The following is a description of a gene set: part of: L1CAM interactions L1 functions in many aspects of neuronal development including axon outgrowth and neuronal migration. These functions require coordination between L1 and the actin cytoskeleton. F-actin continuously moves in a retrograde direction from the P-(peripheral) domain of the growth cone towards the growth cone's C-(central) domain. L1, attached to the actin cytoskeleton via membrane cytoskeletal linkers (MCKs) such as ankyrins (Ankyrin-G, -B and -R) and members of the ERMs (ezrin, radixin, and moesin) family, link this retrograde F-actin flow with extracellular immobile ligands.<br>Forward translocation of growth cone requires not only the CAM-actin linkage but also a gradient of cell substrate adhesion (strong adhesion at the front and weak adhesion at the rear) so that the cytoskeletal machinery is able to pull the cell forward as attachments at the rear are released. This asymmetry is achieved in part by internalizing L1 molecules as they are moved to the rear of the growth cone coupled to retrograde F-actin flow and recycling them to the leading edge plasma membrane.<br>L1 internalization is mediated by phosphorylation and dephosphorylation. The L1 cytoplasmic domain (L1CD) carries an endocytic or sorting motif, YRSLE, that is recognized by the clathrin associated adaptor protein-2 (AP-2). AP-2 binds the YRSLE motif only when its tyrosine is not phosphorylated and triggers L1 endocytosis. SRC kinase associated with lipid rafts in the P-domain membrane phosphorylates L1 molecules on tyrosine-1176, stabilizing them in the plasma membrane. L1 endocytosis is triggered by the dephosphorylation of Y1176 within the C domain. Some of these internalized L1 molecules are transported in an anterograde direction along microtubules for reuse in the leading edge. studied in species Homo sapiens Reactome Pathway: Recycling pathway of L1, and this is the list of marker genes: ACTG1, RPS6KA2, TUBA1C, EZR, SRC, TUBB2B, TUBB6, RDX, TUBA1B, L1CAM, CLTA, TUBB8, SHTN1, AP2A2, RPS6KA5, TUBB2A, CLTC, MAPK1, TUBB3, AP2B1, RPS6KA3, TUBA3D, TUBB4A, RPS6KA4, DNM3, NUMB, AP2S1, KIF4B, TUBA1A, KIF4A, ACTB, TUBB1, RPS6KA1, TUBA4B, TUBA3C, SH3GL2, TUBA4A, DNM2, AP2M1, MSN, DNM1, TUBAL3, RPS6KA6, TUBA3E, TUBA8, TUBB8B, TUBB4B, DPYSL2, AP2A1